The following is a description of a gene set: Human Gene Set: HP_APLASIA_HYPOPLASIA_OF_THE_STERNUM studied in species Homo sapiens Aplasia/Hypoplasia of the sternum, and this is the list of marker genes: GPC3, BUB1B (NCBI Gene Id 701), RBM10 (NCBI Gene Id 8241), NIPBL, SETBP1, RNU4-2, GPC4, ORC6, PCGF2, VAC14, NFIX, ARID1B, FRAS1, ORC1, FRA10AC1, SOX9, NOG, FIG4, LAMA5, LRP2